Given this list of marker genes Clec7a, Il17ra, Rarres2, Ncf1, Gapdhrt, Hamp2, Hrg (histidine-rich glycoprotein), Plcg2, Tslp, Tac1, Mpo, Elane, Gapdh-ps15, Usp15, Defb42, Il36rn, Clec4a3, Vip, Ang, Clec4a1, Ang6, Cxcl1, Spag11a, App, Clec4n, Clec4b2, Clec4a2, Tgfb1, Pomc, Hamp, Fam3a, Spon2, Il17a, Cx3cr1, Pik3cd, Defb19 (defensin beta 19), Npy, Camp, Nlrp10, Gapdhrt2, Clec4d, Ltf, Jagn1, Zbp1, Ctsg, Cotl1, Clec4b1, Card9, Pla2g5, Trim62, Spi1, Ang2, Clec4a4, Il17rc, Arg1, Clec4e (NCBI Gene Id 97322), Leap2, Ang5, Gapdh, Bcl10, Gm12250, Ang4, Gpr15lg, here is a description of the gene set: species: Mus musculus Mouse Gene Set: GOBP_DEFENSE_RESPONSE_TO_FUNGUS Reactions triggered in response to the presence of a fungus that act to protect the cell or organism.